The following is a description of a gene set: Watery voluminous diarrhea resulting from an imbalance between ion and water secretion and absorption. Human Gene Set: HP_SECRETORY_DIARRHEA Secretory diarrhea studied in species Homo sapiens, and this is the list of marker genes: PLVAP, SLC26A3, STX3, UNC45A, SPINT2, SLCO2A1, EGFR, FOXP3, PERCC1, NLRC4, ACSL5, SLC9A3, EPCAM, DEF6